Given this list of marker genes Kmt2a, Kmt2b, Setd4, Setd1b, Setd7, Setd1a, Kmt2c, Kmt2d, here is a description of the gene set: species: Mus musculus Catalysis of the reaction: L-lysyl4- + S-adenosyl-L-methionine = H+ + N6-methyl-L-lysyl4- + S-adenosyl-L-homocysteine. This reaction is the addition of a single methyl group to the unmethylated lysine residue at position 4 of histone H3, producing histone H3K4me. Mouse Gene Set: GOMF_HISTONE_H3K4_MONOMETHYLTRANSFERASE_ACTIVITY